Given this list of marker genes CENPF, SGO2, ZNF107, SMC4, ESM1 (NCBI Gene Id 11082), BRCA2, CENPE, CCDC144A, FAM111B, KIF14, KIF20B, ASPM, here is a description of the gene set: from publication Blanco-Melo D, Nilsson-Payant BE, Liu WC, Uhl S, Hoagland D, Møller R, Jordan TX, Oishi K, Panis M, Sachs D, Wang TT, Schwartz RE, Lim JK, Albrecht RA, tenOever BR (PMID 32416070) Analysis of the transcriptional response to SARS-CoV-2 compared with other respiratory viruses, including MERS-CoV, SARS-CoV-1 (SARS), human parainfluenza virus 3 (HPIV3), respiratory syncytial virus (RSV), and IAV. Human Gene Set: BLANCO_MELO_SARS_COV_1_INFECTION_MCR5_CELLS_UP Genes up-regulated in SARS-CoV-1 infection (MRC5 cells, MOI: 3, 24hpi). studied in species Homo sapiens